The following is a description of a gene set: Reactome Pathway: Prednisone ADME electronically inferred by orthology from the curated human pathway This event has been computationally inferred from an event that has been demonstrated in another species.<p>The inference is based on the homology mapping from PANTHER. Briefly, reactions for which all involved PhysicalEntities (in input, output and catalyst) have a mapped orthologue/paralogue (for complexes at least 75% of components must have a mapping) are inferred to the other species. studied in species Mus musculus part of: Drug ADME, and this is the list of marker genes: Ugt1a5, Cyp3a16, Ugt2b35, Cyp3a44, Serpina6, Hsd11b2, Alb, Akr1c14, Akr1c13, Ugt2b37, Akr1c18, Cyp3a41a, Cyp3a57, Cyp3a13, Cyp3a25, Akr1c6, Ugt2b36, Cyp3a41b, Ugt2b1, Ugt2b38, Cyp3a11, Akr1c21, Akr1c20